Given this list of marker genes Tbx3, Bmp2, Eng, Tbx2, Nfix, here is a description of the gene set: species: Mus musculus The developmental process by which an atrioventricular canal is generated and organized. Mouse Gene Set: GOBP_ATRIOVENTRICULAR_CANAL_MORPHOGENESIS